Given this list of marker genes Irgm2, Bok, Irgm1, Bcl2a1c, Bcl2a1b, Bcl2l1, Bik, Bcl2, Bak1, Bcl2a1d, Bcl2l2, Mcl1, Pxn, Dnm1l, Bax, Igtp, Rack1 (receptor for activated C kinase 1), Bcl2a1a (NCBI Gene Id 12044), here is a description of the gene set: Binding to a Bcl-2 homology (BH) protein domain. Bcl-2-related proteins share homology in one to four conserved regions designated the Bcl-2 homology (BH) domains BH1, BH2, BH3 and BH4. These domains contribute at multiple levels to the function of these proteins in cell death and survival. Anti-apoptotic members of the Bcl-2 family have four BH domains (BH1-BH4). Pro-apoptotic members have fewer BH domains. species: Mus musculus Mouse Gene Set: GOMF_BH_DOMAIN_BINDING